The following is a description of a gene set: The enzymatic release of energy from inorganic and organic compounds (especially carbohydrates and fats) which requires oxygen as the terminal electron acceptor. Human Gene Set: GOBP_AEROBIC_RESPIRATION species: Homo sapiens, and this is the list of marker genes: ATP5MF, MT-ND4, OGDHL, ETFRF1, ATP5F1B, NDUFB9, NDUFV3, COX7A2, MT-CO2, NDUFA7, NDUFB5, NDUFA8, MT-ND2, NDUFB11, BID, COX7B2, ACO2, NDUFA3, IDH3G, NDUFB8, NDUFB4, NDUFS1, CSKMT, STOML2, SDHD, MT-ND6, SNCA, SDHAF4, NDUFS3, COA6, PARK7, MT-ND4L, BCL2L13, COX6A2, MT-ND1, MTCH2, PDHA1, UQCC3, UQCR10, MDH2, NDUFB2, MIR210, COX7B, CBFA2T3, SUCLA2, VCP, CAT, MT-ND5, PDHB, NDUFC1, IDH3A, SHMT2, ATP5PF, MTFR1, ATP5MG, NDUFV1 (NADH:ubiquinone oxidoreductase core subunit V1), NUPR1, COX6B2, NDUFS5, NDUFV2, ATP5F1E, CDK1, NDUFA5, COX5B, UCN, UQCRFS1, COL6A1, RHOA, CCNB1, PDHA2, COX7A1, UQCRQ, COX7A2P2, NDUFS2, KGD4, DNAJC30, ATP5PO, ATP5F1D, NDUFB1, ATP5PD, MDH1B, SLC25A14, CYCS, CS, TRPV4, ATP5IF1, ABCD1, ACO1, DNAJC15, CHCHD10, SUCLG2, NDUFS4, COX7C, CYC1, ISCU, NDUFB7, NDUFA9, MT-CO3, SLC25A23, UQCRB, COX6A1, NDUFC2-KCTD14, MLDHR, UQCRFS1P1, NOP53, NDUFA2, COX8A (cytochrome c oxidase subunit 8A), COX8C, IDH3B, MTFR1L, ATP5ME, PPIF, SURF1, MT-ATP8, UQCRC2, GHITM, FH, MT-CO1, PINK1, UQCRHL, UQCRH, NDUFB3, COQ9, DLAT, IDE, ATP5PB, MACROH2A1, COX5A, NDUFS8, COX7A2L, NDUFB10, ATP5F1A, ANTKMT, NDUFA4, SDHC, NDUFA10, SLC25A51, MFN2, NDUFA6, PANK2, MTFR2, NDUFA1, COX4I2, ARL2, CHCHD2, ACTN3, OGDH, MTCO2P12, NNT, SDHA, NDUFA12, SDHAF2, COX10, SLC25A33, ATP5F1EP2 (NCBI Gene Id 432369), SIRT3, TMEM135, TNF, MT-ATP6, IDH2, ME3, UQCR11, ATPSCKMT, UQCRC1, ATP5F1C, NDUFB6, BLOC1S1, NDUFS7, NDUFA13, NDUFA11, OXA1L, COX4I1, AK4, DGUOK, C2orf69, NDP, NIPSNAP2, MT-CYB (NCBI Gene Id 4519), NDUFAB1, NDUFC2, SUCLG1, SDHB, COX6B1 (cytochrome c oxidase subunit 6B1), MLXIPL (NCBI Gene Id 51085), ATP7A, MSH2, NDUFAF1, MDH1, NDUFS6, ADSL, FXN, DLST, COX6C, TEFM, MT-ND3, UQCC2, IDH1, DLD